The following is a description of a gene set: Mouse Gene Set: GOBP_MACROPHAGE_CHEMOTAXIS The movement of a macrophage in response to an external stimulus. studied in species Mus musculus, and this is the list of marker genes: Myo9b, Csf1, Ccl3, Mst1 (NCBI Gene Id 15235), Mif, Slamf1, Rarres2, Cxcl17, Ptk2b, Ccl2, Hc, Mmp9, C5ar1, Trem1, Gpr35, Edn2, Cx3cl1, Ninj1, Ptprj, Ednrb, Lgals3, Akirin1, Cmklr1, Nup85, Slamf8, Mmp2, Mapk3 (NCBI Gene Id 26417), C3ar1, Stap1, Thbs1, Ccl12, Mdk, Cyp19a1, Csf1r, Ccl21a, Tafa4, Ptk2, Rpl13a, Ccr7, Ccl5, Cklf (chemokine-like factor), Mtus1, Mstn, Mapk1, Mmp28, Tnfsf18, Il34, Trpv4